Given this list of marker genes Kif3a (kinesin family member 3A), Hsp90aa1, Fam76b, Hcls1, Ifng, Nutf2-ps1, Hyal2, Frat2, Tek, Pcm1, Txn1, Hnf4a, Tmem30b, Cep290, Akap5, Pcnt, Chp1, Cdh1, Angpt1, Mapk14, Ube2j1, Ei24, Pdcd5-ps, Ube2g2, Peg12, Apod, Adipoq, Gm14461, Prkd1, Plk3, Il6, Agtr2, Zc3h12a, Chp2, Rab23, Ifi27, Tenm1, Sfn, Cdk1, Ptpn1, Mavs, Ctdspl2, Edem2, Cd81, Derl3, Commd1, Cabp1, Ywhae, Slc51b, Pdcd5, Ptpn22 (protein tyrosine phosphatase, non-receptor type 22 (lymphoid)), Rufy3, Prr5l, Fermt1, Tm9sf4, Xpo1, Psen1, Cd36, Tmem30a, Hdac3, Insig1, Derl2, Wipf1, Camk1, Sirt6, Prkaca, Prpf4b, Anp32b (acidic nuclear phosphoprotein 32 family member B), Snx3, Efcab7, Rangap1, Sumo1, Mapk1, Hm629797, Atp13a2, Cdk5, Bcap31, Trim28, Brca1, Flna, Gas6, Ubr5, Yod1, Ptpn5, Erlec1, Tnfrsf1a, Frat1, Ywhab, Chrm1, Epm2a, Uaca, Ergic3, Pik3r1, Bard1, Zdhhc2 (NCBI Gene Id 76202), Sorl1, Chchd4, Park7, Asph, Kif5b, Pik3r2, Oaz1, Sec16b, Cep131, Shh, Tpr, Ran, Oaz2, Ptpn14, Pdcd10, Oaz3, Gsk3b, Sp100, Mdfic, Camk4, Nolc1, Gper1, Ect2, Sh3tc2, Nup58, Prkcq, Cdkn2a, Lep, Ice1, Vamp2, Ipo5, Rapgef3 (Rap guanine nucleotide exchange factor (GEF) 3), Ep300, Nfkbia, Jup, Pkia, Ubac2, Cdc42, Bag3, Dmap1, Ppm1a, Eif3e, Xpo4, Sirt7, Nup54, Gripap1, Gli3, Zfand1, Bmp4, Septin8, Ripor1, Cwh43, Prkcd, Gcc2, Rab29, Zpr1, Gbp4, Zic1, Ufm1, Slc35d3, Tgfb1, Nup62, Xbp1, Svip, Mdm2, Ptgs2, Akap1, Ptpn11, Edem1, Ndel1, Dctn1, Uhmk1, Arhgap44, Lcp1, Rbm22, Pkig, Kif20b, Jak2, Nf1, Emd, B3gat3, Nutf2, Smo, Hsp90ab1, Os9, Tardbp, here is a description of the gene set: Mouse Gene Set: GOBP_REGULATION_OF_INTRACELLULAR_PROTEIN_TRANSPORT Any process that modulates the frequency, rate or extent of the directed movement of proteins within cells. studied in species Mus musculus